The following is a description of a gene set: Any process in which an organelle is transported to, and/or maintained in, a specific location. species: Mus musculus Mouse Gene Set: GOBP_ORGANELLE_LOCALIZATION, and this is the list of marker genes: Trak2, Cplx2, Mtm1, Chmp1b, Ms4a2, Aspm, Syt10, Rab27a, Ankfn1 (ankyrin-repeat and fibronectin type III domain containing 1), Exoc7, Gpsm1, Def8, P2rx7, Pacs2, Snap29, Klc2, Rab7, Stx5a, Sdc1, Gbf1 (golgi-specific brefeldin A-resistance factor 1, NCBI Gene Id 73518), Mfn1, Xpo1, Spice1, Ncam1, Tpgs1, Rad21l, Kxd1, Kifbp, Stoml2, Rab11a, Racgap1 (NCBI Gene Id 26934), a, Nsl1, S2bpcox16, Lin7c, Nlrp5, Becn1, Spc25, Fmn2, Hsbp1, Rims1, Chmp2b, Grp, Dnm1l, Kif1b, Mos, Magi2, Chmp3, Tprg1l, Trip11, Arf1, Hif1a, Stx7, Ccnb1, Kpnb1, Bsn, Llgl2, Dlg1 (discs large MAGUK scaffold protein 1), Lamp1, Brat1, Sgo1, Ndel1, Myo5a, Kat5, Tmem230, Nectin2, Exoc3, Zw10, Nup88, Ubb, Syndig1, Pex14, Clmn, Stx11, Exoc2 (exocyst complex component 2), Dab1, Cdca8, Bccip, Ctnnb1, Atp13a2 (NCBI Gene Id 74772), Exoc6, Sun2, Spg11, Arl8b, Trim46, Chmp1a, Cln3, Ikbkg, Cdk9, Nppa, Kifc5b (kinesin family member C5B), Gnao1, Kif1a, Ubxn2b, Tmem106b, Champ1, Htt, Sar1b, Pard3b, Opa1, Tcf7l2, Btbd8, Cdh3, Lsg1, Trappc3, Arhgap21, Pdzd8, Bloc1s1, Pcdh17, Tmed10-ps, Sun1, Sirt1, Rb1, Cenpc1, Map2k1, Snhg15, Cluh, Ankrd53 (NCBI Gene Id 75305), Syt11, Tmed10, Syde1, Mark1, Ap1s2, Scn11a, Il4ra, Rcc2, 5730455P16Rik, Arcn1, Chmp7, Unc13c, Esyt2, Kif5c, Uvrag, Clasp2, Stxbp2, Ttl, Mapk8, Cul3, Atcay, Picalm, Gpr15lg, Copg1, Stx16, Calm2, Cdc23, Calm1, Prkcz, Nsfl1c, Gem, Sybu, Spag9, Snap23, Tcirg1, Dync1i1, Snx4, Cenpq, Zbed3, Arfgap3, Armcx3, Trappc11, Mx2, Wasf1, Ltv1, Exoc6b, Eml4, Pip4p1, Snapin, Flcn, Ap3b1, Hgs, Meioc, Rims2, Rnf167, Myrip, Hps6, Tfeb, Tspan9, Ahi1, Ehbp1l1, Iffo1, Synj1, Plekhm1, Ptgds, Rasl2-9, Lmnb1, Nppc, Syt4, Dnm3, Map1s (microtubule-associated protein 1S), Ptk2, Wasl, Trappc13, Atp2a1, Lat, Cdh2, Ap3m1, Lin7a, Vps4b, Ska2, Il13ra2, Gata1, Myo19, Kif16b, Akap9, Nup62, Cdca5, Fes, Fyco1, Tlk2, Lyn, Cdk5, Tle6, Snca, Lrrk2, Stx8, Vmp1, Pik3cg, Stxbp1, Esyt3, Terb1, 1700009N14Rik, Spire1, Bin1, Tor1a, Kat2a, Trappc2, Trappc5, Mapre1, Synj2bp, Rasgrp1, Bhlha15, Map4k2, Mad1l1, Terf1, Polr2m, Gpsm2, Vamp8, Bloc1s2, Pafah1b1, Nlgn2, Pef1, Rbm10, Rab3gap1, Unc13b (unc-13 homolog B), Wdr11 (WD repeat domain 11), Clnk, Gab2, Stk11, Nuf2, Tbc1d23, Trak1, Cdk5rap2, Kif1c, Dmd, Copg2, F8a, Bloc1s6, Nlgn3 (neuroligin 3), Kif5b, Bves, Nmd3, Map2, Plek, Cep63, Chga, Tbccd1, Rab44, Terb2, Kat2b, Lin7b, Pkd1, Itgb1, Ntn1 (netrin 1), Madd, Cep290, Tacc1, Kif2c, Bicdl2, D6Wsu163e, Naglu, Nlrp4f, Sirt2, Bicd2, Ndc80, Agtpbp1, Cadps2, Trappc12, Ap3d1, Adora3, Kif14, Bloc1s5 (biogenesis of lysosomal organelles complex-1, subunit 5, muted), Ctbp2, Stx12, Rrs1, Mcph1, Pdpk1, Pex1, Chmp4c, Cenpf, Tsc1, Plin5, Vamp2, Cenpa, Kif2b, Pex13, Chmp1b2, Dctn1, Fam83d, Scrib, Rab1a, Fhod1, Knl1, Cav2, Llgl1, Rab8a, Spry1, Fgfr2, Ccnb1-ps, Ska1, Atm, Cops5, Sapcd2, Cdk1, Limk2, Apc, Ighe, Unc13a, Dock7, Fgr, Numa1, Ttk, Seh1l, Ap3s1, Ripor1, Tesk1 (testis specific protein kinase 1), Rab17, Prkn, Baiap3, Pdcd10, Cav3, Il13, Bcl2l1, Mdn1, Psrc1, Trappc2l, Spdya (speedy/RINGO cell cycle regulator family, member A), Bicdl1, Spag5, Stx1b, Mad2l1, Cdc42bpa, Ppfia2, Kifc1, Dnm2, Rhot1, Selenon, Spo11, Nde1, Pkhd1, Ska3, Spast, Kcnb1, Cfh, Snap25, Vps33b, Tanc2, Incenp, Pabpc1l, Bub3, Pax6, Fam91a1, Spire2, Riok2, Myo5b, Hdac6 (NCBI Gene Id 20374), Nlgn1, Pinx1, Mfn2, Btk, Slc2a4 (NCBI Gene Id 20528), Snf8, Preb, Ran, Smpd3, Eml3, Tmem201, Ykt6, Ppfia3, Stx17, Mtor, Mlh1, Ooep, Kif28, Ccdc186, Fcer1a, Pla2g3, Mef2a, Esyt1, Eif6, Atp9a, Cep120, Slit1, Borcs5, Trappc6a, Birc5, Nr4a3, Inppl1, Slc18a2, Psen2, Mapt, Mapk15, Nefl, Cftr, Mrgprb1, Mylk2, Gja1, Myo1a, Sphk2, Cdt1, Vps18, Chmp5, Stx19, Kif13a (kinesin family member 13A), Ndrg4, Tmed9, Ccdc66, Rab11b, Nrxn1, Dync1h1, Msto1, Gata2, Clasp1, Borcs6, Rac2, Myh9, Mis12, Tsg101, Pdcd6ip, Dpysl2, Dynlt1b, Bicd1, Nherf1, Arhgef2, Sdc4, Arfgap2, Syn3, Armc1, Mreg, Rabgef1, Chmp4b, Dnm1, Uchl1, Septin5, Wipi1, Nudc, Ect2, Plekhm2, Tacc3, Bloc1s4, Dipk2a, Fam98a, Tac4, Nusap1, Pld2, Kif5a, Syk, Bloc1s3, Epcip, Dtnbp1, Stx4a, Syn1, Tacc2, Rims3, Syne2, Trappc6b, Cdc42, Exoc8, Sdcbp, Gramd2a, Hhex, Tuba1a, Dsn1, Zwint, Pdcd6, Mei1, Ahcyl1, Eipr1, Actr3, Spdl1, Lmna, Actn4, Gpr143, Psen1, Kit, Nup98, Abraxas1, Tex14, Trim58, Fnbp1l, Exoc4 (NCBI Gene Id 30856), Majin, Nefh, Ywhaz, Steap3, Mul1, Hap1, Il4, Sytl2 (synaptotagmin-like 2), Exoc1, Map6, Kifc2, Spry2, Hook3, Stx3, Stx1a, Dynll1, Ralb, Ube2b, Nek2, Klhl12, Stxbp3, Chmp2a, Snap91, Pmf1, Rab3a, Fez1, Fbxw11, Syn2, Kif22, Mlph, Sytl4 (synaptotagmin-like 4), Stk25, Actr10, Khdc3, Slc4a5, Pdzd11, Hmox1, Knstrn, Ap3s2, Misp, Syne1, Crocc, Ptgdr, Trappc10, Calm3, Rnf13, Vps33a, Kash5, Cd84, Myh10, Milr1, Ezr, Myo5c (myosin VC), Map1b, Bltp1, Pclo, Uso1, Vps11, Myo1c, Pcm1, Stam, Ap3m2, Mgarp, Ap3b2, Vps4a, Actr2, Ap1ar, Lamtor1, Abraxas2, Cenpe, Trappc9, Crhr1, Atg14, Sec16a, Hdac3, Nop9, Fcer1g, Lmnb2, Brca2, Cep83, Cfl1, Trappc1, Zfp207, Unc13d (NCBI Gene Id 70450), Atp2a2, Aurkb, Rab34, Pard3, Borcs8, Chp1, Vapb, Ogt, Exoc5, Katnb1, Dctn2, Myo7a, Stx6, Syne3, Cnih2, Ctbp1, Syt6, Adora2b, Kif18a, Pten, Trappc4 (NCBI Gene Id 80545), Rps15, Chmp6, Cadps, Arhgap33os, Cep19 (centrosomal protein 19), Hnrnpu, Foxf1, Septin1, Sdad1, Stard3nl, Mrgprx2, Camk2a, Enkd1, Syt1, Borcs7, Npm1, Lat2, Vapa, Fgf10, Golga2, Spc24, Stx2, Mecp2, Cd300a, Rhot2, Tspan4, Spout1, Agbl4 (ATP/GTP binding protein-like 4), Map4, Sar1a, Itga4, Shroom2, Cbl, Plk1, Pibf1, Stard3